Given this list of marker genes Gtf3c5, Bnc1, Mtor, Macroh2a1, Alkbh2, Bend3, Dhx33, Maf1, Bnc2, here is a description of the gene set: Binding to a DNA sequence encoding a ribosomal RNA. Mouse Gene Set: GOMF_RDNA_BINDING species: Mus musculus